Given this list of marker genes Sirt1, Champ1, Ska2, Mad1l1, Cdt1, Ska1, Aurkb, Kat2b, Mis12, Ndc80, Birc5, Becn1, Cdca8, Cdk1, Kat5, Hnrnpu, Ska3, Nuf2, Incenp, Snhg15, Seh1l, Cenpc1, Kif2c, Cenpe, Mapre1, here is a description of the gene set: species: Mus musculus The cellular process in which spindle microtubules become physically associated with the proteins making up the kinetochore complex in mitosis. Mouse Gene Set: GOBP_ATTACHMENT_OF_MITOTIC_SPINDLE_MICROTUBULES_TO_KINETOCHORE